Given this list of marker genes ID2 (NCBI Gene Id 3398), B4GALT2 (NCBI Gene Id 8704), AKT1, PRPH2, SLC24A2, CREB1, H2AC25, MAPK13, PRIMPOL, MAP3K20, MAPK14, ATR, RRH, IFT20, HRH1 (NCBI Gene Id 3269), GRK1, MDM2, GNAT3, YY1 (NCBI Gene Id 7528), MAP4K3, PER3, HYAL3, B3GAT1, NPM1 (nucleophosmin 1), FOXB1, LRRN4, MTA1, POLH, CAMKMT, NPHP4, MMP1, ATP8A2, ABCA4, FOS (Fos proto-oncogene, AP-1 transcription factor subunit), GNB5, MYC, GUCY2D, BRAF, POLA1, HIF1A, CDKN2D, IL12B, TMEM161A, LRIT1, NFATC4 (nuclear factor of activated T cells 4), SMPD1, HYAL2, OPN1MW2, ASIC2, TUBA1A, COPS9, RO60, LCN2, CDKN1A, HMGN1, GUCA1B, MC1R, DRD1, ATP1A2, TRIAP1, TRPM1, CRY1, GRK7, BHLHE40, GPX1, BRCA2, UNC119, MMP2, TP53INP1, MSH6, KDM1A, RELA, MYO15A, NETO1, CERS1, PBK, RIC8A, TREX1, RHBDD1, PIANP, ZBTB1, GPR52, CRTC1, ST20, KRAS, EYS, DHX36, EXT1, PTPRK, PER1, UBE4B, XPA, ELK1, RPL26, CHRNB2, DYNLRB1, TTC36, MAP3K4, CDK5, EIF2S1, INO80, CRY2 (NCBI Gene Id 1408), OPN4, SDE2, RPE65, KCNC1, CTNS, TP53, GRIN2A, ERCC3, CRB1 (NCBI Gene Id 6107), SERPINB13, MAPK11, SPRTN, PDE1B, NMT2, DCUN1D3, CASP3 (caspase 3), GUCA1ANB-GUCA1A, SCN11A, ATXN1, RGS9, PPP1CA, ITGB1, ELOVL4, RBM4, PER2, OPN1MW3, RHNO1, ERCC5, FECH, PRKAA1, PRKCD, GUCY2F, AGRP, NR2F6, USP1, AQP1, CCDC66, AURKB, GTF2H2, SLC4A10, PIAS1, RBP4, PNPLA2, CCAR2, PML, FRMPD1, RAG1, PCNA, JUND, GRIN1, NPY, GNAQ, CCND1, AANAT, PDE6C, CACNB4, PIERCE1, IL12A, ABCC8, REV1, PLN, COPS3, CUL4B, STK11, HUS1, SDF4, TAF1, METTL3, WRN (WRN RecQ like helicase), NDRG4, TIPIN, NF1, NOC2L, MMP3, CEP250, ADAM2, GNGT1, MAP2K7, TRIM32, SLC1A2, TTR, FBXW7, SLC1A3, MFAP4, COL6A1, NPHP1, DCT (NCBI Gene Id 1638), DDB1, POLD3, GNGT2, RUVBL2, FEN1, TAFA2, CREBBP, CASP7, CDS1, RGS9BP, PPID, NSMCE3, SLC24A4, MMP9, USP28, ZRANB3, COL6A2, NMU, CACNA1F, SIRT1, ROM1, DRD3, DDB2, PPP1CB, BBS10, FBXL21P, CLOCK, BEST1, PLEKHB1, ERCC8, PCP2, RHO, DDHD2, APP, OPN1MW, EI24, CRIP1, BAX, CAT, GNAT2, MEIS2, ATF4, UVSSA, KCNC2, GPR88, SYNGAP1, NMT1, UBE2A, SLC7A11, LRIT3, POLK, GRM6, DEAF1, ABCA7, PPP1CC, NEDD4, XPC, BCL3, REEP6, PARP1, TIMP1, RP1, ATOH7, GRK4, SEMA5B, EIF2AK4, NR2E3, AIPL1, USF1, ERCC2, GPSM2, HYAL1, UBE2B, NLRP1, BAK1, TYR, DRD2 (dopamine receptor D2), PDE6B, CABP4, AKT2, GNA11, GUCA1A, BRSK1, PCLAF, ELANE, HMGCR, RGR, MT-ND3, PPP1R1B, RDH13, RGS14, PITPNM1, IVL, HOXA1, KIT, KMT2A, SIRT6, GNAT1, SAG, RBM4B (RNA binding motif protein 4B), CIRBP, EP300, POLD1, NOG, SIK1, OPN5, MME, FBXL3, RBX1, BMF, DBH, TRPC3, SCARA3, LARGE1, CNGB1, GJA10, OPN1SW, CACNA2D4, NPS, MSH2, COMT, USP2, ERCC6, CRYAA, OPN1LW, ERCC1, SLC24A1, DTL, PDC, PIK3R1, N4BP1, CASP9, ACTR5, TULP1, DUSP1, RPAIN, PDE8B, MAPK10, MEN1, OPN3, CUL4A, RCVRN, EGFR, BCL2, TP53I13, COL6A3, MECP2, ERCC4, MAPK8, CPT1B, TANC1, here is a description of the gene set: Human Gene Set: GOBP_RESPONSE_TO_LIGHT_STIMULUS studied in species Homo sapiens Any process that results in a change in state or activity of a cell or an organism (in terms of movement, secretion, enzyme production, gene expression, etc.) as a result of a light stimulus, electromagnetic radiation of wavelengths classified as infrared, visible or ultraviolet light.